Given this list of marker genes Edn1, Oxtr, Cyp1a1, Bmal1, Rxfp1, Ldoc1, Akr1c18, Kalrn, Nodal, Nrk, Hpgd, Ccl2, Mmp2, Ptafr, here is a description of the gene set: species: Mus musculus The reproductive process in which the parent is separated from its offspring either by giving birth to live young or by laying eggs. Mouse Gene Set: GOBP_PARTURITION